Given this list of marker genes CKB, CKMT2, CKM, CKMT1A, CKMT1B, MAP4K4, NME2, here is a description of the gene set: Human Gene Set: GOMF_PHOSPHOTRANSFERASE_ACTIVITY_NITROGENOUS_GROUP_AS_ACCEPTOR species: Homo sapiens Catalysis of the transfer of a phosphorus-containing group from one compound (donor) to a nitrogenous group (acceptor).